Given this list of marker genes IP6K1, PON1 (paraoxonase 1), PLA2G2D, AADAC, INPP5B, MIR548P, PIK3C2G, APOA5, BPNT1, PIGA, PIK3C2B, MIR29B1, IP6K3, MTMR2, PIK3C2A, PI4K2A, PLCB4, PIGG, MTMR7, CAPN2, PLCD1, INSIG1 (insulin induced gene 1), ABHD12, MIR192, PLA2G1B, LPCAT1, PIP5KL1, PNLIPRP1, SLC44A5, PNPLA3, PGS1, AGPAT2, SCARB1 (scavenger receptor class B member 1), PDGFB, PISD, CHKB (choline kinase beta), PEMT, GALR2, G6PC1, INPP5D, PTPN11, APOA4 (apolipoprotein A4), HTR2C, PLAAT5, MTMR9, GPCPD1, GPAT4, CIDEB, LIPG, PLCG2, PGAP2, ATG14, ITPKC, DDHD1, ABHD12B, NR1H2, DGKI, PI4KB (NCBI Gene Id 5298), MTMR14, DGKH, PIK3R4, OSBPL8, FAAH, PNPLA5, MGLL, DDHD2, FIG4, INPPL1, LMF1, PI4KA, CHPT1, GK, EFR3A, CDS1, INPP5K, SEL1L, CRLS1, DGKE, DPM1, APOF, MTMR4, APOC1, GDE1, ABHD16A, TMEM150A, PGAP4, LDLR, NAPEPLD, MIR30C1, SPATA18, PIGL, PLA1A, TMEM86B (NCBI Gene Id 255043), ABHD3, GDPD3, PLSCR1, INPP5F, PCYT2, DBI, HADHA, PTPMT1, SIK1, RAB38, PDGFA, PIKFYVE, SERINC1, VAC14, OC90, MBOAT7 (membrane bound O-acyltransferase domain containing 7), PLA2G2F, INSIG2, NR1H4, APOC2 (apolipoprotein C2), AGPAT3, SERINC2, PIGK, PHB2, MFSD2A, MPPE1, PIP4K2A, SELENOI, LPL, OCRL, MTMR10, TMX1, PIGC, ATM, PANK2, PCK2, LPIN3, GPLD1, LCAT, PTEN, GPAT2, APOH, ETNK2, PNPLA1, TBL1XR1, MTMR6, PIGT, PIGO (phosphatidylinositol glycan anchor biosynthesis class O), SORL1, DGAT1, AGPAT1, PLCH1, UVRAG, TNXB, LPCAT3 (NCBI Gene Id 10162), ETNK1, LIPA, PIGV, FITM2, PI4K2B, MTM1, PIGF, PLA2G4F, PGP, PCYT1B, PIK3R3, MBOAT1, DAGLB (diacylglycerol lipase beta), CHAT, CTDNEP1, PLA2G15, INPP5A, PIGN, ABHD16B, MTTP, CHRM5, DGKZ, CHKA, CNEP1R1, PITPNM3, PLCL1, PIP4K2C, GPX1, PLCB3, SYNJ1, GK2, ABHD4, DNAJC19, PIP4P1, HTR2A, PLAAT2, BECN1, PLA2G7, PLA2G4C, MOGAT2, TNFAIP8L3, PLD2, PLA2G10, FABP3, PIK3CA (NCBI Gene Id 5290), LPCAT4, ITPKA, GPIHBP1, TAMM41, APOA2, CPS1, INPP5J, PNPLA7, GNB3, GPAM, INPP5E, C3 (complement component 3), ACSL1, LIPI, GDPD1, ENPP6, OSBPL5 (oxysterol binding protein like 5), PIGY, AJUBA, PIP5K1B, INPP4A, AGPAT5, ABHD8, PIP5K1A, PLCB2, ITPKB, SH3GLB1, PLA2G3, PTDSS2, PIPSL, PIK3CB, ENPP2, APOBR, TTC7B, ABHD5, LPIN1, PGAP3, PIGU, GPR82, PLD1, PIK3CG, PIK3R1, PIGB, PTDSS1, PIK3R5, MOGAT1, IMPA1, SLC44A2, SLC44A4, DPM2, PLA2G4E, CAV1, PNLIPRP3, PITPNM2, PLCH2, CDIPT, PLIN5, AGK, AGMO (alkylglycerol monooxygenase), PIGS, MTMR8, PIGQ, INPP1, PIGH, CEPT1, PLA2G4D, PNPLA2, LPCAT2, BPNT2, PLAAT4, TTC7A, INPP4B, DAGLA, MBOAT2, PIP4K2B, DGAT2L6, PNPLA8, SREBF1, SLC30A5, PCK1, PLAAT1, PLAAT3, PIP4P2, EFR3B, FUT1, FBXW7, SLC22A4, PLA2G4A, PLB1, AGPAT4, PLA2G6, PLA2G2C, SMG1, PGAP1, MTMR1, CAV3, NR1H3, ABHD2, PNLIP, BMX, IMPA2, IP6K2, SLC44A1, SMPD4, GAL3ST1, ACP6, DGKD, CETP, HDHD5, LIPF, PIGZ, PLCE1, DPM3, SERAC1, ABHD6, ACSL3, SLC27A1 (NCBI Gene Id 376497), OSBPL10, AVIL, APOE, LYPLA2, TPTE2, LIPC, PITPNM1, PIGM, LPIN2, APOBEC1, SACM1L, PLCL2, CLN3, MECP2, DGAT2, PNLIPRP2, PRDX6, APOB (NCBI Gene Id 338), SLC44A3, ALOX15, FABP5, FAR1, PLA2G2A, PIP5K1C, HYCC1, PIGX, CAT, PAFAH1B1, PIGP, PLA2G2E, TAFAZZIN, DGKA, DGKQ, PNPLA4, CWH43, SLC27A5, DGKB, GK5, PI4KAP2, CIDEC, NKX2-3, ABCA3, LCLAT1, LIPH, MTMR3, NAAA, PLCG1, PLA2G5, SERPINA12, APOC3, PLA2G4B, HTR2B, PNPLA6, PIK3CD, SYNJ2, APOA1, KAT5, THEM5, SH3YL1, AWAT2, THRSP, PCSK9, PIK3C3, MTMR11, PCYT1A, PIGW, GPAT3, PTPRQ, DGKG, IPMK, DGKK, CPT1A, GNPAT, LIPE, SERINC5, GPAA1, MOGAT3, TMEM68, HYCC2, MTMR12, LPGAT1, SIRT1, CDS2, PLCB1, here is a description of the gene set: Human Gene Set: GOBP_GLYCEROLIPID_METABOLIC_PROCESS The chemical reactions and pathways involving glycerolipids, any lipid with a glycerol backbone. Diacylglycerol and phosphatidate are key lipid intermediates of glycerolipid biosynthesis. studied in species Homo sapiens